Given this list of marker genes AXL, NME5, APPL1, ROR1, CDKL5, AKAP7, CMPK1, RIPK3, NRBP1, CERK, INPP4A, ETNK1, SYT14, BCL2L11, STK24, TAOK1, NF1, DKC1 (dyskerin pseudouridine synthase 1), ARHGEF25, GALK2, IKBKE, IRAK2, ATR, SRMS, AAK1, EPHB1, CYLD, PRKAR1B (NCBI Gene Id 645590), XRCC6, CDK9, NR1I2, TRPV5, EPHA6, PFKFB1, CHEK1, TXK, TRPV6, EPHB4, PPP1R17, RPS6KA4, MAP3K20, RAF1, NEK7, PIK3R1, TRIO, NUAK2, PRKAR2A, WWP2, EP300, TPD52L3, PRKACB, PRKRA, GRK4, STK32C, HIPK2, DLG2, HCK, AK3, CDK14, PRKCG, CNP, FIGN, FGFR3, PPARA, TSKS (testis specific serine kinase substrate), ITK, NME6, PRKDC, ERBB3, AKAP4, STK3, FYN, AKAP6 (NCBI Gene Id 9472), DBF4, INPP5D, HECW1, CERT1, SPEG, MAP3K8, RCSD1, CSNK1E, ARHGEF2, PIK3AP1, TICRR, PDXK, EPHB2, PKN1, C17orf75, CDK6, TAOK3, ALK, STK26, TBK1 (TANK binding kinase 1), TGFA, MASTL, DMPK, FOXO4, CSNK2A2, STK33, CPNE1, GZMB, SLC22A18, PRKD2, RPS6KL1, NTRK1, SIK1, CDK8, BRAF, STK32B, COQ8A, XYLB, KDR, CCNB3, GRK6, MAP2K6 (mitogen-activated protein kinase kinase 6), TAF1, MAP3K14, GCKR, CDK11B, PLCB4, ELP1, HGS, PKM, LIMK2, PRKAA1, AKT3, PKLR, PIK3R3, PPARG, PRKD1, GMIP, KALRN, STK32A, VRK3 (NCBI Gene Id 51231), EPHA4, MAK, PPP1R12C, ROS1, RPS6KA6, SYT16, ZC3HC1, BMPR1A, CAMK4, PIK3CG, MAPK8, PACSIN2, NUCKS1, GUCY2C, PHKB, ADK, CDK3, PRKG1, PICK1, MOB3C, LIMK1, MERTK, CAMKV, TERF2IP, SYT4, TRIB1, CKS1B, BTK, CD40, NR1H4, EXOSC10, SYT5, here is a description of the gene set: species: Homo sapiens from publication Firestein R, Bass AJ, Kim SY, Dunn IF, Silver SJ, Guney I, Freed E, Ligon AH, Vena N, Ogino S, Chheda MG, Tamayo P, Finn S, Shrestha Y, Boehm JS, Jain S, Bojarski E, Mermel C, Barretina J, Chan JA, Baselga J, Tabernero J, Root DE, Fuchs CS, Loda M, Shivdasani RA, Meyerson M, Hahn WC (PMID 18794900) Genes required for proliferation of DLD-1 cell (colon cancer with APC deletions), based on shRNA screen. Aberrant activation of the canonical WNT/beta-catenin pathway occurs in almost all colorectal cancers and contributes to their growth, invasion and survival. Although dysregulated beta-catenin activity drives colon tumorigenesis, further genetic perturbations are required to elaborate full malignant transformation. To identify genes that both modulate beta-catenin activity and are essential for colon cancer cell proliferation, we conducted two loss-of-function screens in human colon cancer cells and compared genes identified in these screens with an analysis of copy number alterations in colon cancer specimens. One of these genes, CDK8, which encodes a member of the mediator complex, is located at 13q12.13, a region of recurrent copy number gain in a substantial fraction of colon cancers. Here we show that the suppression of CDK8 expression inhibits proliferation in colon cancer cells characterized by high levels of CDK8 and beta-catenin hyperactivity. CDK8 kinase activity was necessary for beta-catenin-driven transformation and for expression of several beta-catenin transcriptional targets. Together these observations suggest that therapeutic interventions targeting CDK8 may confer a clinical benefit in beta-catenin-driven malignancies. Human Gene Set: FIRESTEIN_PROLIFERATION